The following is a description of a gene set: Human Gene Set: GOBP_N_ACETYLNEURAMINATE_METABOLIC_PROCESS studied in species Homo sapiens The chemical reactions and pathways involving N-acetylneuraminate, the anion of 5-(acetylamino)-3,5-dideoxy-D-glycero-D-galacto-non-3-ulosonic acid., and this is the list of marker genes: CMAS, NANS, AMDHD2, NPL, SLC35A1, ST6GAL1, NAGK, NANP, GNPDA1, GNE, ST3GAL1, GNPDA2 (NCBI Gene Id 132789), RENBP